Given this list of marker genes DDX27, SLC35F2, CLIC2, CD1E, HDAC9, MTMR1, UVRAG, C10orf95-AS1, DHRS3, TRIB2, ITGAX, P2RY14, NREP, BCL7A, SPTBN1, RPS5 (ribosomal protein S5), HMGN1, EI24, SHMT2, RPLP0, RPL19, PDLIM1, RPS2, HMGA1, IL1R2, BUD23, CD59, CCDC86, ELMO1, GSN, HIP1, PRKACB, BANK1, ITGB7, CST3, RPL35, BCL11A, P2RY10, MRPL9, RPS23, RBPJ, PARM1, PPA1, ERG28, PIP4K2A, H3C8, H2BC10, RGS10, RUFY3, H3C11, SNRPD2, CCDC6, SLC2A1, PAK1, FABP5, PRCP, SH3BP4, H2AC14, CCND2, PHACTR1, H2BC5, IL2RG, C2CD2, ARF3, RPS10P5, ATP8B4, RPS10, FLT3, CD1B, GOLGA8A, SIGLEC6, SOX12, BASP1, CST7, AFF3 (NCBI Gene Id 3899), RPL9, IL18R1, HLA-DPB1, DYRK2, ARL4C, IL18, ST13, HOXA9, AXL, PEBP1, IRF4, NET1, ZEB1, EVL, NDRG2, EPB41L2, H2BC8, CD226, RHOF, SEPTIN6 (NCBI Gene Id 23157), HLA-DRB1, VCL, CD1C, LANCL1, CD207, RPSA, ATP1B1, ESYT1, H2BC6, H2BC9, H2AC13, ADAM28, DEXI, ALCAM, CIDEB, CCDC88A, PRMT1, HIVEP2, MAGEF1, HLA-DOA, JHY, ACSF2, C1QBP, PON2, TCTN3, ACSL5, NDUFV2, RPL36, AK2, FBLN2, BZW2, VDAC1, RPS17P5, UPK3A, SLC38A1, H2BC14, DEPTOR, CCR6, COL9A2, CD72, PEA15, ASF1A, SNRPF, HLA-DPA1, CBX5, SNRPE, NDRG1, DCTPP1, TPD52, RPS20, SAMHD1, CACNA2D3, SPINT2, CLEC10A, GPR183, SNRNP25, TAB2, SCRN1, MMD (NCBI Gene Id 23531), CIITA, NDUFV1, HNRNPA0, FCER1A, HLA-DRB6, ADAM8, HERC2, LIMK1, MZT2A, H1-5, EIF3L, HADH, HLA-DOB, HLA-DMA, ATIC, SPATS2L, PFN1, H4C11, RPS6, FBL, YWHAE, DCAKD, H1-4 (NCBI Gene Id 3008), HLA-DRA, FAU, MAP4K1, GDI2, NUP210, VOPP1, LGMN, RPL4, VPS51 (NCBI Gene Id 739), OFD1, SH3BP5, H1-2, TMF1, FAM162A, HINT1, DNAJC15, BIN1, CNN2, PTGDR2 (NCBI Gene Id 9484), NPM3, H4C3, PRKCH, PGM1, here is a description of the gene set: Genes down-regulated in comparison of monocytes from influenza vaccinee at day 7 post-vaccination versus myeloid dendritic cells at day 7 post-vaccination. Human Gene Set: GSE29618_MONOCYTE_VS_MDC_DAY7_FLU_VACCINE_DN from publication Nakaya HI, Wrammert J, Lee EK, Racioppi L, Marie-Kunze S, Haining WN, Means AR, Kasturi SP, Khan N, Li GM, McCausland M, Kanchan V, Kokko KE, Li S, Elbein R, Mehta AK, Aderem A, Subbarao K, Ahmed R, Pulendran B (PMID 21743478) studied in species Homo sapiens Systems vaccinology has emerged as an interdisciplinary field that combines systems wide measurements and network and predictive modeling applied to vaccinology. Here we used the systems vaccinology approach to study the molecular mechanisms underlying th